The following is a description of a gene set: studied in species Homo sapiens In the present study we used Affymetrix oligonucleotide microarrays to produce gene transcription profiles for the major leukocyte types in humans. This comprehensive dataset enabled us to not only establish which genes were expressed in each leukocyte type, but also which genes were expressed in each subset after activation. The used of a comprehensive dataset of gene profiles from all the major human leukocyte subsets enabled a novel and powerful means for identification of genes associated with single leukocyte subsets, or different immune paradigms. Genes up-regulated in comparison of macrophages versus NK cells. from publication Jeffrey KL, Brummer T, Rolph MS, Liu SM, Callejas NA, Grumont RJ, Gillieron C, Mackay F, Grey S, Camps M, Rommel C, Gerondakis SD, Mackay CR (PMID 16474395) Human Gene Set: GSE3982_MAC_VS_NKCELL_UP, and this is the list of marker genes: MARCHF1, CTSH, TMX2, GATM, UGGT2, BSCL2, FER, CLN8, SIGLEC9, CLPB, GALNS, KCNJ1, ITPRID2, STUM, CEP170, ENPP2 (NCBI Gene Id 5168), SCD, RAB4A, HTATIP2, SLC23A2, SHCBP1, TNS1, ANXA5, QPCT, RGS1, HBEGF, GPER1, PLA2G15, M6PR, LYL1, C5AR1, HEBP1, RGS16, ABCG2, TOR3A, CYP51A1, FABP4, RGCC, PIK3CB, PDXK, FNBP1L, MYO5A, VAC14 (NCBI Gene Id 55697), ATP6V1H, APPL1, COX5B (NCBI Gene Id 1329), PUDP, CPM, KIF1C, PTK2 (NCBI Gene Id 5747), MGST3, PSMD14, CMTM6, PCLAF, WWTR1, MGST2, GALNT12, PGRMC1, USP6NL, RBPJ, SERINC3, SMOX, USP32, HLA-DPB1, PRDX3, METTL8, KCTD12, FGGY, NUSAP1, CYBRD1, CLIC2, GPR63, RAB11FIP1, CTNS, SLC43A3, UCHL1, PPARD, VDR, PCBD1, CSF1, PLXNC1, NAIP, ACP2, SLC2A5, DLAT, FABP5, TMEM140, GNG12, DNAJC12, DLGAP5, PCOLCE2, NDUFB6, COL8A2, ZNF804A, GSN, REPS2, MRPL33, MAD2L1BP, CDCA8, TEKT2, GNG5, P4HA2, ASB13, PTEN, CBR1, MACROH2A1, CISH, ATP2B2, PMP22, RMDN3, EPB41L3, PLAUR, CRLF2, C2orf49, CNDP2, ANXA2P1, HMMR, KCTD3, JAG1, PGAM1, PLAU, HMOX1, MKLN1, MSRA, AHNAK2, RAB11A, MIEF1, FCGR2B, PLEK2, SNX13, ARHGEF40, GLRX, BUB1B, DOCK3, ATP5PF, TRIB1, ELOC, PLA1A, STXBP1, VPS37C, TIMP3, GTF2IRD1, RXRA, DYNC1I2, CD83, APOO, EPB41L2, NRIP3, CCDC6, CCL22, QPRT, ARHGAP22, CMAS, BEX4, JUP, SLC47A1, NACC2, EIF4A3, MMP2, MCFD2, TNFSF14, UTP11, STAC, C3, PAQR5, PRSS50, PPP2R3A, LAMP1, ACSL1, PMFBP1, SDCBP, NOP10, CENPU, IDH1, NRBF2, LRRC8B, BAG4, AMPD3 (NCBI Gene Id 272, adenosine monophosphate deaminase 3), ERP44, PLIN3, BHMT2 (betaine--homocysteine S-methyltransferase 2), EML4, DNAJC7, ITFG1, GPR137B, CDKN1A, HIVEP3, NDUFB5, NUMB, CTNNA1, GK, KCNJ2, SLC25A13, MERTK, ACOT7, FTH1 (ferritin heavy chain 1), LDHB, ZNF589, RNASE4